The following is a description of a gene set: from publication Schaefer CF, Anthony K, Krupa S, Buchoff J, Day M, Hannay T, Buetow KH (PMID 18832364) species: Homo sapiens Validated targets of C-MYC transcriptional activation Human Gene Set: PID_MYC_ACTIV_PATHWAY, and this is the list of marker genes: ODC1, PIM1, TRRAP, FOSL1, GAPDH, SMAD3, MTA1, CDC25A, KAT2A, UBTF, PRDX3, HSP90AA1, ENO1 (enolase 1), PFKM, SHMT1, CAD, RUVBL1, HUWE1, EIF4A1, NBN, ACTL6A, HSPD1, BAX, TERT, SLC2A1, LDHA, MMP9, SUPT7L, CDCA7, KAT5, POLR3D, BIRC5, TK1, HMGA1, KIR3DL1, SNAI1, TP53, EIF2S1, SERPINI1, EP300, PMAIP1, CCND2, NME1, IREB2, MAX, RCC1, DDX18, NPM1, TAF4B, RIOX2, TAF9, CDK4 (NCBI Gene Id 92978), HSPA4, TAF10, MTDH, EIF4G1, PDCD10, MYCT1, NME2 (NCBI Gene Id 4831), PTMA, NDUFAF2, TFRC, EIF4E, E2F3, GPAM, RPL11, TAF12, PEG10, BMI1, BCAT1, SMAD4, RUVBL2, LIN28B, NCL, ID2, CREBBP (NCBI Gene Id 1387), SUPT3H, MYC, CCNB1